The following is a description of a gene set: This event has been computationally inferred from an event that has been demonstrated in another species.<p>The inference is based on the homology mapping from PANTHER. Briefly, reactions for which all involved PhysicalEntities (in input, output and catalyst) have a mapped orthologue/paralogue (for complexes at least 75% of components must have a mapping) are inferred to the other species. electronically inferred by orthology from the curated human pathway species: Mus musculus part of: Metabolism of water-soluble vitamins and cofactors Reactome Pathway: Vitamin B5 (pantothenate) metabolism, and this is the list of marker genes: Slc25a42, Pdzd11, Coasy, Slc5a6, Pank3, Vnn1, Slc25a16